The following is a description of a gene set: Patterns of gene expression in the central nervous system are highly variable and heritable. This genetic variation among normal individuals leads to considerable structural, functional and behavioral differences. We devised a general approach to dissect genetic networks systematically across biological scale, from base pairs to behavior, using a reference population of recombinant inbred strains. We profiled gene expression using Affymetrix oligonucleotide arrays in the BXD recombinant inbred strains, for which we have extensive SNP and haplotype data. We integrated a complementary database comprising 25 years of legacy phenotypic data on these strains. Covariance among gene expression and pharmacological and behavioral traits is often highly significant, corroborates known functional relations and is often generated by common quantitative trait loci. We found that a small number of major-effect quantitative trait loci jointly modulated large sets of transcripts and classical neural phenotypes in patterns specific to each tissue. We developed new analytic and graph theoretical approaches to study shared genetic modulation of networks of traits using gene sets involved in neural synapse function as an example. We built these tools into an open web resource called WebQTL that can be used to test a broad array of hypotheses. from publication Chesler EJ, Lu L, Shou S, Qu Y, Gu J, Wang J, Hsu HC, Mountz JD, Baldwin NE, Langston MA, Threadgill DW, Manly KF, Williams RW (PMID 15711545) Neurologically relevant transcripts with highest abundance fold range in brain tissue among mouse strains. studied in species Mus musculus Human Gene Set: CHESLER_BRAIN_HIGHEST_EXPRESSION, and this is the list of marker genes: PPP1CB, HINT1, ACTB, ANKRD13C, CADPS, FOS, MAP2, KIF5A, PRKCE, PSMB5, SYT1, ATP11A, DCTN3, SNHG6, HNRNPA2B1, ATP13A3, FTL, STEEP1, CSRP1, GLO1, ATP6V0B, SCN1A, RABAC1, DYNLL2, A4GALT, GNB1, MARCHF7, UQCRB, KMT2E, XIST, KCTD12 (NCBI Gene Id 80710), ACSL4 (acyl-CoA synthetase long chain family member 4), BBLN, MOBP, ZRANB2, GRIA2, SP3, PPID, MATR3, PLP1, LIN7C